Given this list of marker genes EXTL3, IPO8, SPINK5, TRAC, CARD9, NLRP1, here is a description of the gene set: Severely increased total eosinophil count studied in species Homo sapiens Human Gene Set: HP_SEVERELY_INCREASED_TOTAL_EOSINOPHIL_COUNT Severe increase in circulating eosinophils, usually characterized as more than 1500 eosinophils per microlitre.